Given this list of marker genes DHODH, TSPAN7 (NCBI Gene Id 7102), RPP25, LHPP, RCBTB2, UGT2B28, CREB3L2, B9D1, HSP90B1, AAK1, UPP2, TGFBR2, DAB2IP, PBXIP1, ZMAT2, BAK1, GPR62, OTOP2, GDPD5, MARK2, DDR1, HNF1A, RAPGEFL1, MEF2D, ZMYM6, ZNF710, DOC2B, PHAF1, ANKRD65, ORMDL3, RBM20, KCTD16, EFHC2, PACS1, TNRC6B (NCBI Gene Id 23112), PMEPA1, JADE2, ITPKB, TTYH3, KCNH3, ATP9B, RYBP, IGLON5, B3GNT9, DPPA4, PEDS1, PLPPR2 (NCBI Gene Id 64748), GLIS2 (NCBI Gene Id 84662), CLK2 (NCBI Gene Id 1196), COG6, PPP1R9B, RPP14, IP6K2, FBXL19, MTRF1L, SCN4B, FBXL18, SP7, ATG9A, FGF1, DEDD2, COLGALT2, NIBAN3, CHST15, CARMIL1, MPP2, EFHD2, PNPO, DCHS1, AHDC1, ZFP41, RERE, NFAM1 (NCBI Gene Id 150372), UBE2M, ADGRA1 (NCBI Gene Id 84435), MAP1A, NFIC, STK35, PPARD, SPTBN4, RNF157, APCDD1L, SNX21, NR6A1, SMG7, FZD2, FOXO4, MYD88, MAZ, SNX33, XPO7, EDC3, ATP12A, CTDSP1, MGRN1, MEX3A, SEMA3F, E2F7, CDK16, EIF2B5, PYCR3, ZCCHC24, RTL8C, KSR2, NPTX1, EPG5, CANX, INO80, ORC5, SNRPN, LRRC20, ARNT2, KIF21B, SDK2, ELAVL3, TMEM63C, NOP9 (NOP9 nucleolar protein), NOS1, COPS7A, UBTF, ATP5MF-PTCD1, C10orf90 (NCBI Gene Id 118611), GRAMD1B, RBM42, RAB5B, TRAPPC9, ACBD4, PHF21A, HM13, PTCD1, PDXK, SLC35F1, ANAPC15, TXNRD2, PRND, HTR4, STX1B (syntaxin 1B), PRRT2, NFATC2, ELF4, WDTC1, NTNG2, REEP4, SIGMAR1, PLCXD3, CEP170B, STMN4, CNOT9, MTCL2, CHMP6, ARHGDIG, RILPL1, NFASC, DLC1, IGF1, ADCY9, TSPAN33, ACTMAP, CAMK2G, GRID2, OTUD5, SPINDOC, MOB3B, TSPAN9, RAB1B, SIPA1L3, SNURF, CACNB3, ITGAL, GSKIP, AMZ1 (archaelysin family metallopeptidase 1), LYRM4, POLR3C, PSD3, TSKU, FHL3, TMEM201, THEM5, EPHA2, ZNFX1, CAMKV, ACTR1B, SH3PXD2A, here is a description of the gene set: Human Gene Set: MIR6722_3P Genes predicted to be targets of miRBase v22 microRNA hsa-miR-6722-3p in miRDB v6.0 with MirTarget v4 prediction scores > 80 (high confidence targets). from publication Chen Y, Wang X (PMID 31504780) species: Homo sapiens